The following is a description of a gene set: studied in species Homo sapiens Human Gene Set: GSE37301_PRO_BCELL_VS_CD4_TCELL_DN Genes down-regulated in pro-B cells versus CD4 T cells. Expression profiling of Rag2-deficient Ets1++ and Rag2-deficient Ets1-- mature NK cells and WT bone marrow progenitors, WT T cells, and WT Pro B cells from publication Ramirez K, Chandler KJ, Spaulding C, Zandi S, Sigvardsson M, Graves BJ, Kee BL (PMID 22608498), and this is the list of marker genes: NXPH2, PARP8, SOX11, NRP1, THEMIS, GPR171, APBB2, MAPK8IP1, CYTH3, USP1, PDE2A, PECAM1, USP11, KRT4, HDAC1, ARID5A, DHRS3, TADA2A, BTLA, ADD3, HCN4 (hyperpolarization activated cyclic nucleotide gated potassium channel 4), ADGRD1, ICE1, PRSS41, SOAT2, USP18, FAM133B, HEPACAM, SPINK13, VPS13A, CABP2, CYRIA, PDE7A (phosphodiesterase 7A), MTUS1, SEMA6D, SH3KBP1, RHBDD3, IPCEF1, GBP5, CCL5, ESR1, GAB2, PLXNA3, VCAM1, DCLK2, MICAL3, PCARE, GRAMD1B, FRYL, RNF222, DNTTIP2, KCNK5, SLIT1, KIF6, RLIM, IFT80, CX3CL1, USP28, CORT, TMPRSS11E, EBI3, SERTAD4, UBE2L6, MIR375, SP110, AGFG1, RTP4, ZNRF1 (zinc and ring finger 1), LMTK3, TSPOAP1, STAU2, CHST2, CANX, NAV3, ST6GAL1, WLS, MPZ (NCBI Gene Id 4359), JSRP1, SLAMF6, IRX3, CXCR3, NPSR1, PDE4B, PWWP2A, KLHL3, RAB11FIP4, PPFIBP2, PDCD2, LRIG1, ARHGEF28, ZZZ3, SUSD2, RRAGD (NCBI Gene Id 58528), PHLPP1, DHTKD1, CRCT1, LIMK1, HAUS6, RETN (NCBI Gene Id 56729), VIPR2, EWSR1, PRKCQ, RIPK2, NOD1, IL2, NUDT14, ZIC5, KCNK9, PAFAH1B3, ITPR1, DNAJC6, KCNT2 (NCBI Gene Id 343450), PHGR1 (NCBI Gene Id 649577), SLC14A1, DBN1, GSAP, AURKC, CD3G, JPH2, GALNT9, PLEKHF2, ID4, TRDN, TIMP2, PTPRQ, PLSCR1, PTGER2 (NCBI Gene Id 63381), SVEP1, LEF1, TXK, MARCHF3, PSMB10, MARK1, SMC4, ABTB3, EPHX1 (epoxide hydrolase 1), LTB, MIR383, ABTB2, TNFSF11, RPS15A, IL17RB, NT5E, APOBEC1, OTOF, CLSTN2 (NCBI Gene Id 64084), TNFSF8, SPSB1, TMEM63C, MXRA7, DMPK, MIR128-2, CCR6, DTX4, CADM1, SRSF10, CDC14A, MYO10, IZUMO1R, PALD1, GBP6, CD83, SENP7, NAA50, EVL